Given this list of marker genes Srpk2, Ireb2, Sp3, Bpnt2 (3'(2'), 5'-bisphosphate nucleotidase 2), Zfp871, Cyp1b1, Ube2v2, Dhrs13os, Kif2a, Hnrnpm, Ptbp3, Nipbl, Dnajc3, Gtf2a1, Srsf10, Emc2, Rsrp1, Zfp97 (zinc finger protein 97), Zfp638, Bod1l, Cip2a, Bub1, Kitl, Capn7, Arid1a, Mki67, Arglu1, Fam76b, Poln, Myef2, Casp8ap2, Tmem68, Dipk2a, H1f0, here is a description of the gene set: Mouse Gene Set: BURTON_ADIPOGENESIS_12 Strongly down-regulated at 2 h during differentiation of 3T3-L1 cells (fibroblast) into adipocytes. species: Mus musculus During cellular differentiation and development, it is recognized that many complex molecular mechanisms as well as precise patterns of differentially expressed genes occur in directing precursor cells toward a given lineage. Using microarray-based technology, we examined gene expression across the course of 3T3-L1 adipocyte differentiation. Total cellular RNA was isolated at times 0, 2, 8, 16, 24, 48, and 96 h following treatment with either standard hormonal inducers of differentiation; insulin, dexamethasone, isobutylmethylxanthine (IDX), or IDX plus trichostatin A (TsA), a histone deacetylase inhibitor and potent adipogenic inhibitor. cRNA was synthesized from cellular RNA and hybridized to high density Affymetrix MG_U74Av2 microarray gene chips containing 12,488 cDNA/Expressed Sequence Tags (ESTs) probe sets. From the IDX-only treated cells, all probe sets that were either unchanged or differentially expressed less than 2-fold throughout differentiation with respect to time 0 preadipocytes were excluded from further analyses. This selection resulted in a net of 1686 transcripts, 859 were increased in expression, and 827 were decreased in expression at least 2-fold across differentiation. To focus in on genes that were more specific to differentiation, the same analysis was performed on IDX plus TsA-treated non-differentiating cells and all probe sets from the IDX-only group that exhibited similar expression profiles in the non-differentiating TsA-treated group were excluded leaving a total of 1016 transcripts that were regulated only under differentiating conditions. Six hundred and thirty-six of these transcripts were elevated at least 2-fold and 380 exhibited a decrease in expression relative to time 0 preadipocytes. This group of genes was further analyzed using hierarchical clustering and self-organizing maps and resulted in the identification of numerous genes not previously known to be regulated during adipocyte differentiation. Many of these genes may well represent novel adipogenic mediators and markers of adipogenesis. from publication Burton GR, Nagarajan R, Peterson CA, McGehee RE Jr (PMID 15033539)